The following is a description of a gene set: Enables the transfer of sulfate ions, SO4(2-), from one side of a membrane to the other. studied in species Homo sapiens Human Gene Set: GOMF_SULFATE_TRANSMEMBRANE_TRANSPORTER_ACTIVITY, and this is the list of marker genes: UCP2, SLC26A8 (solute carrier family 26 member 8), SLC26A4, SLC26A2, SLC25A10 (solute carrier family 25 member 10), SLC26A1, SLC26A10P, SLC13A4, SLC13A1, SLC26A3, SLC26A9, SLC26A6, SLC26A7, SLC26A11, SLC26A5